Given this list of marker genes IRAK1, NCF1C, FARP2, SIDT2, SKAP2, GM2A, MS4A1, IGKV4-1, GRK3, ALCAM, TFEB, DTX4, HLA-DOB, HLA-DPA1, CORO1C, CD1D, AGPAT5 (NCBI Gene Id 55326), MARCHF1, SNX3, PDLIM1, IGLV1-44, DHTKD1, TAGLN (transgelin, NCBI Gene Id 6876), HLA-DMA, GGA2, OSBPL10 (oxysterol binding protein like 10), CSF2RB, BMS1P20, CD86, SIK1, TOP6BL, MAP3K8, FCGR2A, EHD3, C11orf24, HLA-DRA, RUBCNL, TMT1A, COCH, PRCP, ADK, PAX5, SH2B2, TSPAN13, TSPAN3, FIG4, MZB1 (NCBI Gene Id 51237), IGLV3-19, GNG7, GRB2, FAM3C, SCN3A, LILRB2, RHBDF2, SEL1L3, CYBB, BHLHE41, PTPN1, SETBP1, VPS37B, COBLL1, ITM2C, CD22, DDAH2, P2RX5, FAM30A, MBD4, HLA-DQA1, TPD52, POU2AF1, SIPA1L3, IRAG2, CTSH, CD72, EAF2 (NCBI Gene Id 55840), HCK, OPN3, JCHAIN, CD24 (CD24 molecule), MEF2C, ZFTA, PLCG2, CLIC4, SWAP70, BEND5, FGR, SYK, CLMN, QRSL1, TBC1D9, HLA-DRB6, ABCB4, ZNF532, BCL2L2, RHOQ, CHST15, IGHA1, MEF2A, CD180, CD79B, GSE1, STX7, LAT2, BTK, BASP1, CBFA2T3, PCDH9, RASGRP3, DEF8, FCGR2B, LAMC1, KMO, CACNA1A, CD79A, B4GALT1, BCL11A, ORAI2, IGKV1D-13, VPREB3, FCHSD2, TCF4, IGLJ3, COL9A3, IGKV3-20, HLA-DPB1 (major histocompatibility complex, class II, DP beta 1), DNMBP, USP6NL, RNASE6 (ribonuclease A family member 6), BANK1, HLA-DMB, CD40, CDK14, ZBTB32, PNOC (prepronociceptin), SLC37A1, CD1C, PAOX, CD37, HLA-DQB1, SNRNP25, SMC6, PSEN2, IGLL3P, STAP1, SLC2A6, IGHM, IFI30, KYNU, MARCKS, PKIG, ALOX5, SLC7A7, IGHD, ATP10D, CD74, PIP5K1B, TLE1, LYN, TCF3, SLC17A9, SCPEP1, YBX3, SHMT2, FCRL2, TNS3, KIAA0930, LRRK1, BTN2A2, FCER2, HLA-DRB1, IGKC, TUBB6, PRKCD, LY86, IRF8, GUSBP11 (NCBI Gene Id 91316), RAB31, E2F5, FCGR2C, TNFRSF17, HHEX, HSPA6, SPIB, CYRIA, LILRB1, TCL1A, GRN, AKR1A1, ITGAE, ADAM28, SCRN1, BLK, DENND3, NCOA3, CD19, BLNK, here is a description of the gene set: from publication Hutcheson J, Scatizzi JC, Siddiqui AM, Haines GK 3rd, Wu T, Li QZ, Davis LS, Mohan C, Perlman H (PMID 18275831) Gene expression profile studies have identified an interferon signature in whole blood or mononuclear cell samples from patients with systemic lupus erythematosus. This study was designed to determine whether specific lymphocyte and myeloid subsets freshly isolated from the blood of systemic lupus erythematosus patients demonstrated unique gene expression profiles compared to subsets isolated from healthy controls. studied in species Homo sapiens Genes down-regulated in comparison of systemic lupus erythematosus CD4 T cells versus systemic lupus erythematosus B cells. Human Gene Set: GSE10325_LUPUS_CD4_TCELL_VS_LUPUS_BCELL_DN